Given this list of marker genes Tbk1, Sik3, Rps6kb1, Akt1, Nckap1l, Armh4, Deptor, Ep300, Otud7b, Usp9x, Gsk3b, Otud5, here is a description of the gene set: Any process that modulates the frequency, rate or extent of TORC2 signaling. studied in species Mus musculus Mouse Gene Set: GOBP_REGULATION_OF_TORC2_SIGNALING